The following is a description of a gene set: from publication Chen Y, Wang X (PMID 31504780) Mouse Gene Set: MIR_7084_3P studied in species Mus musculus Genes predicted to be targets of miRBase v22 microRNA mmu_miR_7084_3p in miRDB v6.0 with MirTarget v4 prediction scores > 80 (high confidence targets)., and this is the list of marker genes: Ep300, Cmpk2, Tdpoz1, Selenon, Raph1 (NCBI Gene Id 77300), Cadm3, Pif1, Fgf18, Rictor, Serpini1, Gnaq, Itgbl1, Pkia, Trp53inp1, Cd300lb, Kdm4c, Bcl2l11, Ppp1r3b, Pmfbp1, Ina, Car10, Cbl, Csf3r, Ogfrl1, Tiparp, Aff4, Sra1, Clock, Castor2, Ddx56, Itgb3, Tab3, Myom3, Frmd5, Hapstr1, Sh2d2a, Tob1, Fat3, Tead4, Ankrd17, Fut4, Ildr2, 5730455P16Rik, Dnmt3a, AI987944, Slamf1, Cdc42se2 (NCBI Gene Id 72729), Zfp91, Magi3, Taf4, Pax9, Sgip1, Eif4ebp2, Golga4, Tmem184b, Nadk2, D630045J12Rik, Aif1l, Ppfia2, Traf6, 2810021J22Rik, Plxna4, Kras, Ston2, Kdm5a, Ctf2, Lrp8, Septin4, Col4a4 (NCBI Gene Id 319847), Zfp326, Zfyve28, Rap2c, Mapk1, Shank2, Twist1, Ppp4r1, Dhx15 (DEAH-box helicase 15), Slc49a4, Nopchap1, Tgfbr1, Unc80, Kcna6, Tbc1d12, Osbp, Eef2, Spop, Sass6, Syt14 (NCBI Gene Id 329324), Ahcyl1, Rbm15b, Plat, Psd3, Dcaf1